The following is a description of a gene set: Pathway Definition from KEGG: 40S == mRNA == 60S Translation initiation. Pathway ID: N01317. Pathway type: Reference. Pathway class: nt06171 SARS coronavirus 2 (SARS-CoV-2). studied in species Homo sapiens Human Gene Set: KEGG_MEDICUS_REFERENCE_TRANSLATION_INITIATION, and this is the list of marker genes: RPS14, RPL11, RPL27, RPS24, RPS5 (ribosomal protein S5), RPS27, FAU, RPL13, RPL17, RPL6, RPS2, RPS19, RPSA, RPL4, RPL7A, RPL10A, RPS20, RPS11, RPLP1, RPL41, RPL28, RPL34, RPL26, RPL37, RPS7 (NCBI Gene Id 6201), RPS17, UBA52 (ubiquitin A-52 residue ribosomal protein fusion product 1), RPS13, RPS6, RPL19, RPS4Y2, RPL36A, RPL8 (ribosomal protein L8), RPL15, RPS23, RPS3, RPL35, RPS4Y1, RPL22, RPL23A, RPS8, RPL24, RPLP0, RPL10, RPS26, RPS15A, RPS18, RPS28, RPL7 (ribosomal protein L7), RPS25, RPL18, RPS29, RPL29, RPL18A, RPS21, RPS12, RPL5, RPS15, RPL27A, RPL14, RPS3A, RPL36, RPL12, RPL30, RPL31, RPS27A, RPL23, RPS10, RPS16, RPL35A, RPL9, RPL3, RPL32, RPLP2 (NCBI Gene Id 6181), RPL13A, RPS4X, RPL38, RPS9, RPL21, RPL39, RPL37A